The following is a description of a gene set: species: Mus musculus Mouse Gene Set: MIR_9718 from publication Chen Y, Wang X (PMID 31504780) Genes predicted to be targets of miRBase v22 microRNA mmu_miR_9718 in miRDB v6.0 with MirTarget v4 prediction scores > 80 (high confidence targets)., and this is the list of marker genes: Nmt2, Zc3h12a, E2f3, Gpr137b, Hspa9, Col4a1, Mmp16, Atp2a2, Kdm5b, Tmem33 (transmembrane protein 33), Shpk, Blm, Kdm7a, Rp1l1, Hmgb3, Nol4, Bcl6, Oc90, Cckar, Epha3, Pitx2, Avpr1a, Tsnax, Dcx, Dmc1, Ugt8a (NCBI Gene Id 99902), Camk4, Acbd6 (NCBI Gene Id 72482), Chd7, Eaf1, Atg4a, Arl8b, Vwce (von Willebrand factor C and EGF domains, NCBI Gene Id 71768), Prtg, Gsap, Ktn1, Osbp2, Gins4, Traf3, Mtmr14, Nfat5, Zfp276, Zbtb21, Arih2, Col19a1, Il20ra (interleukin 20 receptor, alpha), Niban1, Chd9, Prpf39, Ntrk2, Srrm4, Fndc5, Stk40, Garin5b (golgi associated RAB2 interactor family member 5B), Zcchc12, Vcan, Sipa1l2, Lsm14a, Sdc2, Rsbn1l, Rc3h1, Birc6, Kctd15, Scn9a, Clvs1 (clavesin 1), Zxdc, Ccdc50, Snx12, Zdhhc1, Popdc3, Zfp704, Mfsd6, Pdss2, Lims2, Ifi47